Given this list of marker genes CIMAP1A, BBC3, MED13L, SAXO2, TRDMT1, SPATA31D4, ONECUT2, SBNO1, PARD3B, LONRF2, BBS2, KCNJ5, FAM241A, SLCO4C1, SEL1L, FAM86C1P, F2R, EIF5B, IFT57, RANBP6, SC5D, IBSP, PAGR1, C11orf54, SNRNP40, LRP8 (LDL receptor related protein 8), C6orf120, NR4A3, SLC1A2 (solute carrier family 1 member 2), AGAP1, B3GAT1, PRRC1, SKIL, ZFX, SF3B1, SRI, RC3H1, IQGAP2, TMOD3, HOMER1, RIMS2, ROCK2, MBOAT1, ALDH1B1, FOXJ3, RBMXL1, MAPK6, PPM1D, PDE10A, SLC44A1, COPG1, DGAT2L6, APOBEC3B, CES5A, CHUK, ALOX5, ARL6IP6, CEBPG (NCBI Gene Id 1054), JRKL, ARIH1, ATRX, AAK1, LPP, CDC37L1 (NCBI Gene Id 55664), GANC, DNAJC3, CAB39, MTF2, ARID4B, PPP3CB, SBF2, ELMOD2, GEM, REST, BRCA2, CACNA2D1, SNAPC1, FAM86B2, ATP6V1C1, CD47, WDHD1 (NCBI Gene Id 11169), KIAA1549L, ROBO1, TUBGCP3, MRPL58, RECK, KHDRBS3, PNLDC1, SUZ12 (SUZ12 polycomb repressive complex 2 subunit), CDV3, MYL12A, FGF7, TIAM1, LRCH2, ENG, GASK1B, MYSM1, MYLK4, LRATD2, ABL1, NEK1, RNF111, ACSL6, HYCC1, GPR89B, PGGT1B, MFAP3L, PIGR, DDI2, KCNQ5 (NCBI Gene Id 56479), GFOD2, ZNF713, SESN3, PEX11A, SLC35A5, NUDT13, SPTSSB, FAM120C, ALKAL2, ZNF717, MMP16, CNOT9, SCAI (suppressor of cancer cell invasion), PPP4R2, PCSK1, FRZB, SOX21, CXXC4, LSM14A, THAP1, CD5L, PGRMC1, EHF, COMMD6, ZBTB2, EGLN1, CERT1, GRAMD1C, FLOT1, EEF2KMT, MIER3 (NCBI Gene Id 166968), B3GLCT, RAB31, PCNP, MIA2, CROT, ASCL2, ABCC9, SCN9A, DIPK2A, ZIC1, HOXA10, CCDC34, MFSD6, ZNF721, CEP135, GARIN2, CBLB, RMDN2, ETS1, SH3GLB1 (SH3 domain containing GRB2 like, endophilin B1), ESYT3, WT1, TTC14, TAB3, MORN4, SGMS1, PLA2R1, KAT2B, VGLL3, ATXN7L1, FBXW7, SLIT2, TMEM135, ACTR2, KRT222, CLPX, ADGRL4, C2orf69, SPATA31D3, ALDOB, FOXN3, ZFP1, SCAMP1, RHOA, ADRA1A, DENND1B, A1CF, SYNPR, HYCC2, PGBD1, PLPPR4, G2E3, TUT7, ZNF706 (NCBI Gene Id 51123), ZBTB25, MINDY2, TTC19, SLC16A7, FAM120A, EIF4EBP2, GALNT17, SEC23B, COL19A1, GPR89A, SEPHS1, CLDN20, GPR180, SLC25A31, PDCD1LG2, ILDR2, here is a description of the gene set: Genes predicted to be targets of miRBase v22 microRNA hsa-miR-29a-5p in miRDB v6.0 with MirTarget v4 prediction scores > 80 (high confidence targets). species: Homo sapiens from publication Chen Y, Wang X (PMID 31504780) Human Gene Set: MIR29A_5P